The following is a description of a gene set: part of: Signaling by NTRK1 (TRKA) Reactome Pathway: PI3K/AKT activation studied in species Homo sapiens PI3K/AKT signalling is a major regulator of neuron survival. It blocks cell death by both impinging on the cytoplasmic cell death machinery and by regulating the expression of genes involved in cell death and survival. In addition, it may also use metabolic pathways to regulate cell survival.The PI3K/AKT pathway also affects axon diameter and branching and regulates small G proteins like RhoA (Vanhaesebroeck, B and Waterman, MD, 1999), which control the behaviour of the F-actin cytoskeleton. Moreover, through its connection with the TOR pathway, it promotes translation of a subset of mRNAs., and this is the list of marker genes: PIK3CB, PIK3CA, NGF, PIK3R2, NTRK1, PIK3R1, IRS2, RHOA, IRS1